Given this list of marker genes Tubgcp6, Tubgcp5, Tubg1, Tubg2, Topors, Pde4b, Bloc1s2, Nme7, Cdk5rap2, Mark4, Tubgcp4, Nedd1, Tubgcp2, Mzt1 (NCBI Gene Id 76789), Tubgcp3, Mzt2, here is a description of the gene set: studied in species Mus musculus A multiprotein complex composed of gamma-tubulin and other non-tubulin proteins. Gamma-tubulin complexes are localized to microtubule organizing centers, and play an important role in the nucleation of microtubules. The number and complexity of non-tubulin proteins associated with these complexes varies between species. Mouse Gene Set: GOCC_GAMMA_TUBULIN_COMPLEX